Given this list of marker genes DAXX, CHEK2, MLST8, UBB, PPP2R1B, PPP2CA, PHF20, TP53, AKT1, MAPKAP1, PPP2R5C, PRR5, PDPK1, USP7, RFFL, RNF34 (NCBI Gene Id 96268), CCNA2, MDM2 (MDM2 proto-oncogene), CDKN2A, RICTOR, CDK2, UBA52, SGK1, AKT3, CCNG1 (cyclin G1), PPP2CB, RPS27A, USP2, MTOR, CDK1, ATM, UBC, CCNA1, AKT2, PRDM1, PPP2R1A, MDM4, here is a description of the gene set: studied in species Homo sapiens part of: Regulation of TP53 Activity TP53 (p53) tumor suppressor protein is a transcription factor that functions as a homotetramer. The protein levels of TP53 are low in unstressed cells due to MDM2-mediated ubiquitination that triggers proteasome-mediated degradation of TP53. The E3 ubiquitin ligase MDM2 functions as a homodimer/homo-oligomer or a heterodimer/hetero-oligomer with MDM4 (MDMX).<p>Activating phosphorylation of TP53 at serine residues S15 and S20 in response to genotoxic stress disrupts TP53 interaction with MDM2. In contrast to MDM2, E3 ubiquitin ligases RNF34 (CARP1) and RFFL (CARP2) can ubiquitinate phosphorylated TP53. Binding of MDM2 to TP53 is also inhibited by the tumor suppressor p14-ARF, transcribed from the CDKN2A gene in response to oncogenic signaling or oxidative stress. Ubiquitin-dependant degradation of TP53 can also be promoted by PIRH2 and COP1 ubiquitin ligases. HAUSP (USP7) can deubiquitinate TP53, contributing to TP53 stabilization.<p>While post-translational regulation plays a prominent role, TP53 activity is also controlled at the level of promoter function, mRNA stability and translation efficiency. Reactome Pathway: Regulation of TP53 Expression and Degradation